The following is a description of a gene set: from publication Chen Y, Wang X (PMID 31504780) species: Mus musculus Mouse Gene Set: MIR_542_5P_MIR_6966_5P Genes predicted to be targets of miRBase v22 microRNA mmu_miR_542_5p, mmu_miR_6966_5p in miRDB v6.0 with MirTarget v4 prediction scores > 80 (high confidence targets)., and this is the list of marker genes: Rlbp1, Srsf12, 1810030O07Rik, Hoxa11, Dusp13a, Sgcz, Slc66a3